The following is a description of a gene set: ADORA2B mediated anti-inflammatory cytokines production Human Gene Set: REACTOME_ADORA2B_MEDIATED_ANTI_INFLAMMATORY_CYTOKINES_PRODUCTION species: Homo sapiens, and this is the list of marker genes: GNB3, GNG2, PRKAR2B, ADCY1, GNAT3, PRKAR1B, CREB1, ADORA2B, GNAI2, GNG10, GNAI1, ADCY7, GNB5, GNG11, GNAZ (NCBI Gene Id 2781), GNG13, PRKACG, ADCY4, GNG4, GNAS, ADCY2, IL6, GNG3, GNGT1, PRKAR1A, PRKAR2A, GNG12 (G protein subunit gamma 12), ADCY9, GNG8, GNGT2, GNB1, ADCY3, GNB4, GNAI3, ADCY8, PRKACB, ADCY6, ADCY5 (adenylate cyclase 5), GNG7 (G protein subunit gamma 7), GNG5, PRKACA, GNB2, PRKX